Given this list of marker genes Atp5f1c, Atp5pd, Atp5po, Atp5me, Atp5mc1, Atp5mc3, Atp5mk, Dmac2l, mt-Atp6, Atp5pf, Atp5f1e, Atp5mg, Atp5mc2, Atp5mf, Atp5mj, Atp5pb, Atp5f1d, Atp5f1b, mt-Atp8, Atp5f1a, here is a description of the gene set: Formation of ATP by chemiosmotic coupling studied in species Mus musculus Mouse Gene Set: REACTOME_FORMATION_OF_ATP_BY_CHEMIOSMOTIC_COUPLING